Given this list of marker genes WWC1, S100A12, UGT8, LAMC1, NR1H3, CEBPA, FRY, SORCS2, PTPN21, DEGS1, ECM1, C11orf86, REEP6, B4GALT4, SERPINE1, GATA2, VTN, NASP, TNFAIP8, NPTX1, PARVA, SPRR3, ANPEP, DUSP19, WNT4, SRSF11, CYP26A1, NMRK1, TFAP2A, TH, CYP11A1, BMP2K, SKP2, DSC2, PECAM1, KRT71 (keratin 71), ASPH, TCF19, PEG10, HTR2C, CRAT, ANXA8, MICAL2, OSBPL1A, RNF144A, PMEL, PIM1 (NCBI Gene Id 82453), ALPP, GRHL1, CYP4F8, COL21A1, AGXT, GDPD5, CYRIA, UCA1, NAGA, TCF7L2, CSF3R (NCBI Gene Id 1441), STS (NCBI Gene Id 6802), NT5E, ACAA2, KRT5, LAMB1, PLD1, VGLL1, SUB1, OBSL1, TMEM139, CACNA1D, ACACB, KRT14, FOS, ABCG1, ZNF831, FYN, CDC42EP3, PIGY, PPARG, BLNK, ACSF2, IL18, LIMCH1, PLCL2, IGF2BP3, SLC16A5, GPAT2, DHRS2, CEP170, SMPDL3A, SLC18B1, KCTD12, COX7B, PC, IGFBP3, FERMT2, VWDE, ENSG00000291065, TCIRG1, CLSTN3, HSD17B1, SGCE, PROM2, ADAMTSL4, VSIR, FHL2, GRAMD1C, SEMA5A, PRKAG2, ACSL5, GAS1, ME2, SRI, PKDCC, DUSP9, GNAI1, GRAMD2A (GRAM domain containing 2A), ORC1, MTARC1, THSD7A, ALOX5, MMRN2, PTGER4, ALDH3B1, SEPTIN6, DPEP2, POU5F1, MEGF6 (NCBI Gene Id 1953), PALM, CRISPLD2, LINC01300, SLC25A37, ITSN1, FSD1, FHL1, DST, SNORD123, DEPDC1, PTPN2, DOCK10, HERC4, PRKAR2B, GLDC, SLC39A10, COL12A1, SMIM2-AS1, XDH, CLMP, LINC02806, FAM13A, ADIRF, here is a description of the gene set: Human Gene Set: GOZGIT_ESR1_TARGETS_UP Genes up-regulated in TMX2-28 cells (breast cancer) which do not express ESR1) compared to the parental MCF7 cells which do. species: Homo sapiens from publication Gozgit JM, Pentecost BT, Marconi SA, Ricketts-Loriaux RS, Otis CN, Arcaro KF (PMID 17726467) We have used a novel variant of the human oestrogen receptor (ER)-positive MCF-7 cell line, TMX2-28, as a model to study breast cancer. TMX2-28 cells show no detectable levels of mRNA or protein expression for the ER and express basal cytokeratins (CKs) 5, 14, and 17. cDNA microarray comparison between TMX2-28 and its parent cell line, MCF-7, identified 1402 differentially expressed transcripts, one of which was, phospholipase D1 (PLD1). Using real-time RT-PCR, we confirmed that PLD1 mRNA levels are 10-fold higher in TMX2-28 cells than in MCF-7 cells. We next examined PLD1 expression in human breast carcinomas. Phospholipase D1 mRNA levels were higher in breast tumours that expressed high-mRNA levels of basal CKs 5 and/or 17, but PLD1 mRNA levels were not significantly higher in ER-negative tumours. Phospholipase D1 protein was overexpressed in 10 of 42 (24%) breast tumours examined by IHC. Phospholipase D1 was overexpressed in 6 of 31 ER-positive tumours and 4 of 11 ER-negative tumours. Phospholipase D1 was overexpressed in three of the four tumours that showed high CK5/17 expression. Five PLD1-positive tumours were negative for phospho-Akt expression, but positive for phospho-mammalian target of rapamycin (mTOR) expression. The other five PLD1-positive breast tumours showed positive expression for phospho-Akt; however, only two of these cases were positive for phospho-mTOR. In this study, we report that PLD1 and phospho-mTOR are coexpressed in a subset of phospho-Akt-negative breast carcinomas.